The following is a description of a gene set: Numerous histone and DNA-binding domains in CHD, MTA, MBD and RBBP proteins contribute to the recruitment of the NuRD complex to DNA, where it appears to interact simultaneously with two adjacent nucleosomes. Recruitment to specific target genes is additionally mediated by protein-protein interactions between NuRD complex components and sequence-specific transcription factors, some of which are represented in this pathway. species: Homo sapiens part of: NuRD complex assembly Reactome Pathway: Interaction of NuRD complexes with transcription factors, and this is the list of marker genes: PCK1, ZNF687, MBD2, CHD4, NR2F2, PHF6, H2BC17 (H2B clustered histone 17), H2BC11, NR2C2, H2AC6, H3-3A, H2BC9, ZNF592, H2BC4, H2AC14, ZMYND8, CHD3, H2BC12, H2AC4, G6PC1, IKZF3, MTA1, H2BC26, RBBP7, H2BC12L, GATAD2B, FBP1, H2AC7, H2BC5, H2AC20, H2AX, ZNF532, H2BC15, HDAC2, IKZF1, H2BC13, GATAD2A, H2AB1, TCF19, ZNF827, H2AJ, IKZF2, H4C1, MBD3, CHD5, H2BC1, HDAC1, H3C1, CDK2AP2, H2BC14, H2AZ2, H2AC18, H2BC21, H3C15, MTA3, RBBP4, CDK2AP1, H2BC3, MTA2